Given this list of marker genes Mul1, Rnf7, Vhl, Asb8, Ubd, Commd4, Asb17, Kctd7, Nedd8 (neural precursor cell expressed, developmentally down-regulated gene 8), Fbxo17, Fbxw4, Spsb3, Fbxl13, Cul4a, Asb10, Fbxo30, Psmb4, Ccnf, Gan, Psmd1, Cish, Klhl5, Psma4, Kbtbd8, Kctd6, Lrr1, Dcun1d1, Psmd12, Fbxl8, Fbxw9, Fbxl15, Psmc3, Cops6, Psmc6, Klhl11, Rbbp7, Fem1b, Fbxl3, Dcaf13, Dcun1d5, Hif1a, Commd7, Klhl41, Asb5, Fbxl7, Spsb2, Uchl3, Btbd6, Lmo7, Dcaf6, Fbxo27, Ubb, Asb16, Fbxl21, Wsb1, Fbxl16, Fbxo31, Fbxo10, Commd10, Socs2, Psmd6, Psma7, Vcp, Fem1a (NCBI Gene Id 14154), Klhl13, Fbxo40, Dtl, Ccdc22, Fbxl14, Asb18, Fbxo32, Ddb1, Asb9 (ankyrin repeat and SOCS box-containing 9), Epas1, Psma2, Hif3a, Psmb5, Fbxl5, Asb11, Psmb6, Commd1, Psmc2, Psmd13, Dcaf4, Ube2d1, Psma6, Asb14, Psmc1, Commd5, Wsb2, Senp8, Rps27a, Fbxo9, Socs3, Fbxl4, Psma5, Psmb7, Dcaf10, Kbtbd13, Psmd7, Psma1, Ufd1, Dcaf5, Btbd1, Asb12, Psma3, Fbxl19, Psmc5, Ankrd9, Psmc4, Cul4b, Cul1, here is a description of the gene set: species: Mus musculus part of: Post-translational protein modification Reactome Pathway: Neddylation This event has been computationally inferred from an event that has been demonstrated in another species.<p>The inference is based on the homology mapping from PANTHER. Briefly, reactions for which all involved PhysicalEntities (in input, output and catalyst) have a mapped orthologue/paralogue (for complexes at least 75% of components must have a mapping) are inferred to the other species. electronically inferred by orthology from the curated human pathway